The following is a description of a gene set: Human Gene Set: HP_ABNORMAL_MUSCLE_FIBER_PROTEIN_EXPRESSION An anomalous amount of protein present in or on the surface of muscle fibers. This feature may be appreciate upon immunohistochemical investigation of muscle biopsy tissue. species: Homo sapiens Abnormal muscle fiber protein expression, and this is the list of marker genes: CRPPA, TTN, FKTN, COL6A3, SELENON, TMEM43 (NCBI Gene Id 79188), LAMA2, DAG1, POMK, COL6A2, HMGCR, GMPPB, SYNE2, LMNA, MYOT, COL6A1, FKRP (NCBI Gene Id 79147), POMT1, DYSF, FHL1, GFER, POMT2, LARGE1, SYNE1, POMGNT1, COL12A1, MYH7, CRYAB, EMD, DMD, CAV3, SNUPN, GOSR2